Given this list of marker genes CAPZA1, TUBB4B, ARCN1, SCFD1, GFPT1, B4GALT3, GOSR1, USO1, NUDT14, ARFGAP3 (ADP ribosylation factor GTPase activating protein 3), SPTBN2, TUBB4A, GBF1, TMEM115, DPM3, ACTR10, PRKCSH, LMAN1, TRAPPC2, ST3GAL5, ST8SIA5, ACTR1A, ARFGAP1, SEC22B, TUBB3, UBC, CAPZB, RPS27A, TUBB2A, RFT1, DCTN4, COPE, SERPINA1, ST6GALNAC1, UBXN1 (NCBI Gene Id 92151), PGM3, NANS, MCFD2, MPI, CALR, LMAN1L (NCBI Gene Id 79748), SEC24B, TRIM13, NSF (NCBI Gene Id 4905), ST8SIA3, CHST10, ST8SIA4, ST3GAL3, DYNC1I1, TGFA, UGGT2, GLB1, EDEM1, CTSZ, AREG, TUBA4B, ALG2, SEC31A, TUBA3D (tubulin alpha 3d), CNIH2, EDEM3, SEC16B, ALG3, ENGASE, ALG6, MAN1A2, GFPT2, MOGS, INS, COG6, MAN2A1, UGGT1, TMED9, SEL1L, CANX, ALG13, LMAN2, DHDDS, SEC24D, RNF103, CTSA, TRAPPC10, MIA2, TMED10, MIA3, CAPZA2, RAB1B, TRAPPC6B, GNPNAT1, UMOD, MAN1B1, TFG, ANKRD28, ST6GALNAC3, TRAPPC9, COL7A1, DCTN2, ANK3, CAPZA3, COG4, DDOST, MGAT4B, TMED3, CHST8, B4GALT6, SRD5A3, LHB, TUBB8B, OST4, ALG11, DCTN3, KDELR3, SYVN1, GFUS, ALG8, SEC23IP, RNF139, TUBB8, HK1, DCTN1 (dynactin subunit 1), NAPB, GMPPB, ALG10B, COG1, TRAPPC3, B4GALT2, DERL2, ARF3, FOLR1, PSMC1, TUBA3E, GORASP1, COPB1, CSNK1D, DYNC1LI1, ALG12, COG7, DYNLL1, GMPPA, ST6GAL2, RPN1, PPP6R3, CD55, SPTB, ANK2, STT3A, LMAN2L, CNIH1, NEU4, ALG10, DPM1, FUCA1, ALG14, TRAPPC2L, DYNLL2, NAPA, CMAS, MAGT1, FPGT, F8, MAN2A2 (NCBI Gene Id 55485), VCP, TUBAL3, SPTAN1 (NCBI Gene Id 6709), ST8SIA2, COPG2, SEC22C, ARF4 (NCBI Gene Id 378), ARF5, GANAB, OSTC, FUT3, DYNC1H1, NEU2, KDELR2, YKT6, COG5, RNF5, MGAT2, RNF185, ST8SIA1, TMEM258 (transmembrane protein 258), MGAT4C, PMM1, TUSC3, COPA, UBA52, RPN2, RENBP, PPP6R1 (protein phosphatase 6 regulatory subunit 1, NCBI Gene Id 22870), GRIA1, SEC16A, ST3GAL4, CD59, ALG5, DAD1, MAN1C1, NUS1, ST3GAL6, ST6GALNAC5, TRAPPC1, SLC35A1, PDIA3, RAB1A, ST8SIA6, COPZ2, TMED7, F5, DCTN5, PPP6C, CNIH3, ALG1, B4GALT5, MGAT5, GOLGB1, DYNC1LI2, ALG9, NAPG, TUBB1, MARCHF6, TUBA1C, NEU3, CGA, COPG1, FUT8, SEC31B, TUBA3C, BET1, MGAT4A, COPB2, STT3B, COPZ1, NPL, B4GALT4, B4GALNT2, GNE, UBB, B4GALT1, GMDS, SPTA1, KDELR1, DYNC1I2, NGLY1, BET1L, NANP, ARF1, DHRSX, ST3GAL1, ANK1, DOLPP1, TUBB6, SAR1B, MPDU1, STX5, DERL1, DPAGT1, SEC24C, TRAPPC4, ST6GALNAC4, SEC13, STX17, OS9, SLC17A5, CTSC, AMDHD2, ASGR1, MVD, PREB, SLC35C1, ARFGAP2, ST6GALNAC2, COG8, TBC1D20, SPTBN5, ST6GAL1, TUBB2B, GOSR2, ST3GAL2, SPTBN1, PMM2, FCSK, COG2, MANEA, GOLGA2, FUOM, ST6GALNAC6, TRAPPC6A, DCTN6, TUBA8, TMED2, MAN1A1, MGAT3, SEC22A, SEC23A, EDEM2, DOLK, SEC24A, SPTBN4, DPM2, MGAT1, TRAPPC5, TUBA4A, UAP1 (NCBI Gene Id 6675), COG3, RAD23B, ASGR2, NEU1, NAGK, TUBA1A, MLEC, TUBA1B, AMFR, here is a description of the gene set: studied in species Homo sapiens Asparagine N-linked glycosylation Human Gene Set: REACTOME_ASPARAGINE_N_LINKED_GLYCOSYLATION